The following is a description of a gene set: species: Mus musculus Blood vessel formation when new vessels emerge from the proliferation of pre-existing blood vessels and contribute to the series of events that restore integrity to damaged vasculature. Mouse Gene Set: GOBP_VASCULAR_WOUND_HEALING, and this is the list of marker genes: Hif1a, Slc12a2, Gata2, Mcam, Cxcr4, Tafa5, Smoc2, Tnf, Xbp1, Foxc2, Cd34, Vegfb, Kdr, Adipor2, Hpse, Serpine1, Vegfa, Ndnf, Alox5, Npr2